The following is a description of a gene set: Any process that increases the rate, frequency or extent of a cellular process that is involved in the progression of biochemical and morphological phases and events that occur in a cell during successive cell replication or nuclear replication events. studied in species Homo sapiens Human Gene Set: GOBP_POSITIVE_REGULATION_OF_CELL_CYCLE_PROCESS, and this is the list of marker genes: CDC16, UBXN2B, SIN3A (SIN3 transcription regulator family member A), SKA3, RHOA, IL1B, CDC14B, DMRT1, MIR372, NDC80, EPGN, PHIP, GPSM2, DTL, UBE2C, PRAP1, PLCB1, DDRGK1 (DDRGK domain containing 1), TNF, CHMP3, CDC25A, GEN1, ESPL1, KNL1, OPN1MW, SMC4, NCAPG, MDM2, MIR515-1, MIR208A, USP19, KCNA5, CDK10, CD28, CDC7, PLCG2, KAT2B (lysine acetyltransferase 2B), MIR214, FGF8, E2F7, CCND1, CYP1A1, MIR519D, CPSF3, PHOX2B, BIRC5, BUB1, SMC2, SPAG5, BECN1, NCAPD2, MIR520H, SKA1, CIT, HNRNPU, MAP10, HSPA2, DBF4B, RGCC, CDCA8, PDGFRB, RCC2, NEUROG1, WNT10B, GLI1, KAT5, SPAST, MAD1L1, KMT2E, SVIL, SLF1, DRD2, SIRT2, FGF10, CDC42, SPHK1, RPTOR, PRKCE, MSX2, CEP120, NCAPD3, EXOC7, CCNB1, SH2B1, SOX15, NPM2, IL1A, CDC14A, NPM1, INO80, TBX2, MIR221, PLK4, PPP1R35, RXFP3, RAB11A, CDK4, IGF1, SLF2, CCDC15, POLDIP2, TAS2R13, ANKRD31, CDC25C, PDGFB, CRNN, POC1A, RRM2B, ANXA1, WIZ, PKP3, AKT1, CUL4B, UBE2B, ARF6, ADAMTS1, SMARCD3, ANKRD17, CCND2, MACROH2A1, CDC23, TGFA, RANBP1, RAD51B, KIF3B, WNT4, XRCC3 (X-ray repair cross complementing 3), RHNO1, MAP3K20, CDK1, INSR, PTENP1-AS, TFDP1, DYRK3, NPR2, MRGPRX2 (NCBI Gene Id 117194), MTA3, OPN1LW, MAPK15, ANAPC11, CDC73, VPS4B, CXCR5, DDX11, MIR520A, OPN1MW2, STRA8, LEF1, E2F8, RAD18, PRDM9, MBLAC1, BTC, PLRG1 (NCBI Gene Id 5356), SASS6, DLGAP5, FBXO5, NUP62, OR2A4, DYNC1H1, NCAPH2, RAB11FIP4, IGF2, ROCK2, TP63, FAM83D, CSPP1, CCND3, MSX1, WNK1, RAB11FIP3, UBE2E2, ZNF16, NANOGP8, RAD51AP1 (RAD51 associated protein 1), CDC14C, WNT5A, CDCA5, CUL4A, EDN1, CENPJ, FEN1, MIR29A (NCBI Gene Id 407021), STOX1, RRM1, EGFR, MTBP, RACGAP1, MAD2L1BP, LSM10, KIF14, PKN2, TPR, DDX3X, EGF, NSFL1C, CHEK2, POC1B, TAS1R2, MIR21, BRD4 (bromodomain containing 4), CCNE2, MED1, PBX1, NUSAP1, CCNE1, CDC20, RAD51C, SMC5, KIF23, MIR495 (NCBI Gene Id 574453), DBF4, MEIOSIN, ECT2, STIL, CUL3, EZH2, PKP4, KLHL18, CDC6, NCAPG2, PAF1, TGFB1, CDC25B, ANAPC7, DRD3, DYNC1LI1, AURKB, ANAPC5, NSMCE2 (NCBI Gene Id 286053), PLSCR1, RAD21, AIF1, TBX20, TERT, PIWIL2, RB1, RDX, HOXA13, RRM2, PPP1R10, LSM11, SSTR5, OOEP, CENPV, PAGR1, DDR2, NUMA1, AURKC, FGFR1, SFPQ, ADAM17, SMPD3 (sphingomyelin phosphodiesterase 3), SMC6, AURKA (aurora kinase A), INCENP, MAD2L1, NCAPH, LRP5, DAZL, EREG, STXBP4, ATAD5, KIF20B, NUDT16 (nudix hydrolase 16), ATRX, TMOD3, INS, EDN3, MEPCE, MIR222, GIPC1, CEP295, OR1A2, EIF4G1